Given this list of marker genes MZT1, DYNLT2B, NLRP3, BIRC5, DYNC2I1 (dynein 2 intermediate chain 1), here is a description of the gene set: A microtubule organizing center found in interphase cells, which organize a longitudinal array of three to five MT bundles from the nuclear envelope during interphase. Each MT bundle is composed of two to seven MTs arranged in an antiparallel configuration, with the dynamic MT plus ends extending toward the cell tips and stable minus ends near the nucleus. Human Gene Set: GOCC_INTERPHASE_MICROTUBULE_ORGANIZING_CENTER species: Homo sapiens